The following is a description of a gene set: IFNs are highly pleiotropic cytokines also endowed with marked anti-angiogenic activity. In this study, the mRNA expression profiles of endothelial cells (EC) exposed in vitro to IFN-alpha, IFN-beta, or IFN-gamma were determined. We found that in HUVEC as well as in other EC types genes were upregulated (>2-fold increase) by IFNs, including genes involved in the host response to RNA viruses, inflammation, and apoptosis. Interestingly, genes showed a >5-fold higher induction by IFN-alpha in EC compared to human fibroblasts; among them, the gene encoding the angiostatic chemokine CXCL11 was selectively induced by IFN-alpha in EC along with other genes associated with angiogenesis regulation, including CXCL10, TRAIL, and guanylate binding protein 1 (GBP-1). These transcriptional changes were confirmed and extended by quantitative PCR analysis and ELISA; whereas IFN-alpha and IFN-beta exerted virtually identical effects on transcriptome modulation, a differential gene regulation by type I and type II IFN emerged, especially as far as quantitative aspects were concerned. In vivo, IFN-alpha-producing tumors over-expressed murine CXCL10-11, GBP-1 and TRAIL, with evidence of CXCL11 production by tumor-associated EC. Overall, these findings improve our understanding of the anti-angiogenic effects of IFNs by showing that these cytokines trigger an anti-angiogenic transcriptional program in EC. Moreover, we suggest that quantitative differences in the magnitude of the transcriptional activation of IFNresponsive genes could form the basis for cell-specific transcriptional signatures. Human Gene Set: GSE3920_UNTREATED_VS_IFNB_TREATED_ENDOTHELIAL_CELL_UP from publication Indraccolo S, Pfeffer U, Minuzzo S, Esposito G, Roni V, Mandruzzato S, Ferrari N, Anfosso L, Dell'Eva R, Noonan DM, Chieco-Bianchi L, Albini A, Amadori A (PMID 17202376) species: Homo sapiens Genes up-regulated in endothelial cells: untreated versus interferon beta., and this is the list of marker genes: IL18, GABPA, FBXO3, LRATD2, ACKR3, GAS6, CHKB, TRPM7, MARK2, SPIN1, CHCHD10, IGLC7, GXYLT1, KBTBD2, CDT1, VPS4A, ANKRD13A, PDCD6, LIMK1, PMM2, SLC25A20, RTP4 (NCBI Gene Id 64108), FUT11, KLF6, CSF1R, BNIP3L, PBXIP1, F2RL1, RGS20, LGALS3, MSL1, AQR, ST7L, ARID1A, LIMK2, DCBLD1, HMX3, DTD2, MTMR9 (NCBI Gene Id 83651), CTBP1, DUSP18, SH2D1A, EZR, FOSB, CLCF1, FOXP4 (NCBI Gene Id 116113), PITPNC1, CBX5, YPEL5, JCHAIN, ASPH, RNASE4 (NCBI Gene Id 6038), OSER1, ANKRD11, NHSL2, SLC6A20, JUN, CCDC81, KCTD20, KBTBD7, BID, SSH2, CNTROB, RUNX2, GABPB2, OVGP1, SLC25A25, ZCCHC2, ITSN1, DOCK2, MAP4K4, PID1, BICRAL, HLA-DRA, STAG2, CELF2 (CUGBP Elav-like family member 2), ZFP36, NIPAL3, AFF3, GTF2I, ECT2, PAQR8, LANCL2, TMIGD1, ETS1, ZSCAN29, TMEM183A, RGS2, PTTG1, ALOX12, CDK19, TSGA10, DCK, CCNI, SFT2D2, PTGDR, DPEP3, SKA3, NEK11 (NCBI Gene Id 79858), KLRG1, HTATSF1 (HIV-1 Tat specific factor 1), MTMR12, AP1G2, SMAD4, N4BP2, PCNT, CABLES2, UBALD2, AP1M1, VANGL2, C2CD5, ST8SIA4, PLCXD2, CHDH, KLRK1 (NCBI Gene Id 22914), UBE2D2, IL15, GRAMD1A, PDPR, TANGO2, N4BP2L1, IGLL1, MAU2, PDS5B, MCMBP (minichromosome maintenance complex binding protein), MFSD14B, CYB5R1, TXK, CA2, MYO1G, THBD, SIK1, ADAMDEC1, MYO1D, FZD6, CXCR4, TINF2, NSD3, HEBP1, URB1, CASP7, MCU, SVIL, KLF13, ISYNA1, CENPL, SIGIRR, TACC1, VEZF1, MARCHF7, USP6NL, MTDH, PPP1R21, MTUS1, SMG6, ORAI2, CD86, PPM1A, KDM5A, HYDIN, MRTFA, ABCC4, IL1RL2, LPL, NXPH2, PRKAB2, CERCAM, VIRMA (NCBI Gene Id 25962), NCF1, SERPINI1, PIGC, BUB3, SH3D19, MROH2A, KIF2C (NCBI Gene Id 11004), WDR82, HIGD1C, KLF2, POLR3C, LEPROT, ANGEL2, MUC13, IFNAR1, UAP1, LYRM9, NAAA, DDX4, LRP10, FBXO22, DHDDS, TMC7, DPY19L1, STMN1, RET, RERE, ADGRV1, ACOX2, KLF3, RFK, SLC25A45